The following is a description of a gene set: species: Homo sapiens Human Gene Set: GSE27786_BCELL_VS_CD8_TCELL_DN Each fraction of mouse hematopoietic cells was purified by cell sorting from bone marrow of 8-week-old C57BL/6 mice, and its gene expression was analyzed. from publication Konuma T, Nakamura S, Miyagi S, Negishi M, Chiba T, Oguro H, Yuan J, Mochizuki-Kashio M, Ichikawa H, Miyoshi H, Vidal M, Iwama A (PMID 21540074) Genes down-regulated in comparison of B cells versus CD8 T cells., and this is the list of marker genes: USPL1, ZNRF1, PPM1J (NCBI Gene Id 333926), PAQR8 (NCBI Gene Id 85315), LSM14B, MTHFD1L, CLINT1, HS1BP3, DOK7, C2CD2, SLC13A2, GALNT12, STXBP5, KCNH2, CGAS, GRP, AHCYL2, CLU, NAA10, C4orf46, ART4, EZH1 (enhancer of zeste 1 polycomb repressive complex 2 subunit), PRSS44P, USP38, MEX3B (NCBI Gene Id 84206), NDFIP2, TMEM260, STOX2, GIMAP4, NDUFS2, FBXO32, IGF2R, MAB21L3, KLF3, COX18, RAP2B, CD84, GFRA3, SLC35B4, RPS10, MLX (NCBI Gene Id 6945), PRRC2B, TMTC4, EEF1G, TNFRSF18, VWF, GLUD1, SRP9, ZNF292, TBX21 (NCBI Gene Id 30009), SLC35G1, DNAJB4, ITFG1, SSBP4, PLA2G3, ANXA11, CYSRT1 (NCBI Gene Id 653325), B3GALT6, BZW2, SMAD4, AQP9, ANXA2, GABRR2, ATP10A, POGK, PRKDC, GOLM1, RPLP0, STMN4, SETX, SEMA3B, ITGAL, RASA2, METTL24, ST6GALNAC5 (NCBI Gene Id 81849), DPP4, MYCBP2, DDX21, COL1A2, CPLANE1, AIFM2, REPS1, SIM1, GRAMD2B, ADGRE5, HK1, SLC25A20, MTFR1L, PATJ, RRAD, CFHR2, AIRN, PDIA2, RNF19A, GOSR1, ACOT7, RPL7, CXorf38 (chromosome X open reading frame 38), PRXL2C, PITPNM1, MPP7 (MAGUK p55 scaffold protein 7), ACAP3, OTOS (otospiralin), TLE4, DNAH8, CEACAM20, MSGN1, FRMD4B, RPS3, SYCE3, KIZ (NCBI Gene Id 57166), ZNRF4, BIVM, SLC39A4, ATP6V0A2, C16orf90, FAM86B2, EFHD2, TMC4, EMX1, PRRT1, SMOX, PREB (NCBI Gene Id 115725), MRPS34, AMN, C5orf34, WFIKKN1, RBP7, TBXA2R, FASTKD1, ORAI1, VWC2, GABRR1, MBNL1, MECR, BSCL2, UBA1, INTS5, KDM1A, IL4R, GNPTG, IFIT1B, CASP8, GMFG, FOXO3, FBLIM1 (filamin binding LIM protein 1), KLF15, CEND1, FGF13, TOP1MT, BSPRY (B-box and SPRY domain containing), PHOX2A, UPP2, DNAAF5 (NCBI Gene Id 54919), ADAMTS19, DOCK10, EIF3M, AGPAT3, ARHGAP1, ENPP4, IGIP, AP3S1, USE1, SLC25A4, UROS, BST2 (bone marrow stromal cell antigen 2), CHURC1, CC2D1B, ITPK1, ZNF274, COPG1, WAPL, BCL9L, DIO2, MPPE1, NPEPL1, TNP2, CREBL2, GZMB, VPS28, SLC49A4, TPBG, HSF4, PARK7, MARCHF2, SYNJ1, HECA, PDCD4, MESD, PPP4R2, GBP7, H2AJ (H2A.J histone), NDUFA4L2, GPR65, MMS19, ARL15, SHC4, TMEM100, NPDC1